The following is a description of a gene set: Any process that regulates the rate, frequency, or extent of gene silencing by RNA. Gene silencing by RNA is the process in which RNA molecules inactivate expression of target genes. Mouse Gene Set: GOBP_REGULATION_OF_GENE_SILENCING_BY_REGULATORY_NCRNA studied in species Mus musculus, and this is the list of marker genes: Zfp36, Il6, Mirlet7a-2, Mecp2, Adar, Mael, Pum2, Tial1, Carlr, Tent2, Ripk1, Eloc, Tnrc6c, Tgfb1, Dgcr8, Stat3, Prkra, Pum1, Fxr1, Trim71, Tarbp2, Mir154, Fmr1 (fragile X messenger ribonucleoprotein 1), Hnf1a, Zswim8, Lin28a, Dnd1, Bcdin3d, Lin28b, Trp53, Zmpste24, Elob, Bmp4 (NCBI Gene Id 12159), Zc3h10, Ago2, Mir361, Elavl1, Trub1